The following is a description of a gene set: species: Homo sapiens part of: NR1H2 and NR1H3-mediated signaling Reactome Pathway: NR1H2 & NR1H3 regulate gene expression linked to lipogenesis The liver X receptor α (LXRα or NR1H3) and LXRβ (NR1H2) are nuclear receptors that are activated by endogenous oxidized derivatives of cholesterol known as oxysterols (Janowski BA et al. 1999; Jakobsson T et al. 2012). NR1H2 and NR1H3 act as whole-body cholesterol sensors and their activation results in a net elimination of cholesterol from the body and amelioration of the plasma lipoprotein profile by mobilizing cholesterol from the periphery (Venkateswaran A et al. 2000; Repa JJ et al. 2000a; Ishibashi M et al. 2013). NR1H3 (LXRα) and NR1H2 (LXRβ) also contribute to lowering of whole-body cholesterol levels by shifting acetyl-CoA units from cholesterol de novo biosynthesis to fatty acid synthesis. NR1H2 or 3-induced hepatic lipogenesis in rodents and humans is mediated by direct upregulation of sterol regulatory element-binding protein 1 (SREBF1), the main regulator of hepatic lipogenesis that controls the transcription of genes involved in fatty acid biosynthesis (Schultz JR et al. 2000). NR1H2 & NR1H3 may activate lipogenic gene transcription directly by biding LXR responsive element (LXRE) found in the promoter regions of several genes, such as fatty acid synthase (FAS or FASN) and stearoyl-CoA desaturase 1 (SCD1) (Repa JJ et al. 2000b; Yoshikawa T et al. 2001; Joseph SB et al. 2002; Chu K et al. 2006). Mice carrying a targeted disruption in the NR1H3 (LXRα) gene were deficient in expression of FAS, SCD1, ACC, and SREBF1 (Peet DJ et al. 1998). Mice ablated of both NR1H3 and NR1H2 showed defective hepatic lipid metabolism decreasing lipogenesis by 80% and were resistant to obesity (Repa JJ et al. 2000; Kalaany NY et al. 2005; Beaven SW et al. 2013). Further, the administration of the synthetic NR1H2 or NR1H3 ligands to mice triggered induction of the lipogenic pathway and raised plasma triglyceride levels (Schultz JR et al. 2000). These studies demonstrate the role of NR1H3 (LXRα) and NR1H2 (LXRβ) in the control of lipogenesis., and this is the list of marker genes: NRIP1, SREBF1, RXRB, RXRA, NR1H3, NR1H2, ANGPTL3, FASN, SCD